Given this list of marker genes PAXIP1, POLL, DNTT (DNA nucleotidylexotransferase), PRKDC (protein kinase, DNA-activated, catalytic subunit), XRCC5, LIG4, DCLRE1C, RIF1, XRCC4, NHEJ1, POLM, XRCC6, TP53BP1, here is a description of the gene set: Human Gene Set: KEGG_MEDICUS_REFERENCE_NON_HOMOLOGOUS_END_JOINING Pathway Definition from KEGG: TP53BP1+RIF1+PAXIP1 -> Ku == DNAPKC -> DNAPK+ARTEMIS -> DNAPK+POLX -> DNAPK == LIG4+XRCC4+XLF species: Homo sapiens Non-homologous end-joining. Pathway ID: N01445. Pathway type: Reference. Pathway class: nt06506 Double-strand break repair.